The following is a description of a gene set: Reactome Pathway: RHO GTPase Effectors studied in species Mus musculus electronically inferred by orthology from the curated human pathway part of: Signaling by Rho GTPases This event has been computationally inferred from an event that has been demonstrated in another species.<p>The inference is based on the homology mapping from PANTHER. Briefly, reactions for which all involved PhysicalEntities (in input, output and catalyst) have a mapped orthologue/paralogue (for complexes at least 75% of components must have a mapping) are inferred to the other species., and this is the list of marker genes: Dvl2, Pfn2, Dynll1, Ppp2r5d, Men1, Kntc1, Wasf3, Tubb4b, Actr3, Tuba1b, Myl6, Nup85, Gopc, Cdc42, Mad1l1 (NCBI Gene Id 17120), Wasf1, Ppp2r5b, Cyba, Cyfip2, Klc4, Nf2, Ppp2r1b, B9d2, Tuba3b, Tuba4a, Ncf2, Tuba1a, Klc3, Ar, Kif2c, Ska1, Cenpm, Dlg4, Fmnl2, Rhpn1, Ptk2, Diaph2, Arpc5, Spc24, Mrtfa, Kif2b (kinesin family member 2B), Xpo1, Myl9, Cenpe, Cenps, Prkca (protein kinase C, alpha), Arpc2, Mapk14, Pkn1, Clasp1, Tubal3, Noxa1, Actr2, Pdpk1, Nckipsd, Rtkn (NCBI Gene Id 20166), Calm1, Dync1li2, Kif5b, Sfn, Ncf1, Myh14, Tuba1c, Mapk11, Ndel1, Tubb6, Rhob, Nde1, Cenpu, Cenpt, Cdc25c, Lin7b, Dvl3, Myh10, Evl, Ywhae, Aurkb, Mapk3, Cenpq, Noxo1, Arpc4, Ctnnb1, Pak3, Nudc, Rac2, Tubb4a, Ndc80, Cenpa, Ktn1, Plk1, Cdh1, Cenpn, Ppp1r14a, Nup133, Itgb3bp, Ppp2r5a, Zwilch, Seh1l, Grb2, Ywhah, Mis12, Mad2l1, Dvl1, Tubb2b, Pfn1, Tuba8, Nox3, Pik3c3